Given this list of marker genes Bmal1, Clock, Cry1, Per1, Phb1, Crebrf, Cry2, here is a description of the gene set: Any process that stops, prevents or reduces the frequency, rate or extent of nuclear receptor-mediated glucocorticoid signaling pathway. species: Mus musculus Mouse Gene Set: GOBP_NEGATIVE_REGULATION_OF_NUCLEAR_RECEPTOR_MEDIATED_GLUCOCORTICOID_SIGNALING_PATHWAY